Given this list of marker genes H2BC6, H2BC21, HMGA1, CCNA1, H3-4 (NCBI Gene Id 8290), H2AX, TERF2IP, POT1, UBN1, H4C3, H2BC15, TP53, H2AC6, H4C5, H2AC8, H2AC20, H1-0, H2BC7, H2BC17, EP400, H2AC19, H2BC3, MRE11, ASF1A, H2BC1, H2BC26, H2AC4, H1-4, H4C11, H2AB1, KAT5, H2AJ, H4C15, H2BC14, H1-5, H2BC10, ATM, CDKN1B, CDK2, H2AC14, CCNA2, H2BC9 (NCBI Gene Id 8345), TINF2, H2BC11, HIRA, H2AC7, H4C12, LMNB1, CABIN1, H2AC18, NBN, RAD50, CCNE1, CDKN1A, H4C8, H2BC12, H2BC12L, H4C13, H2AZ2, H4C2, H4C9, HMGA2, H4C1, ACD, H4C16, H2BC4, H2BC5, TERF1, H2BC13, CCNE2, H2BC8, H4C6, TERF2, H1-1, H4C14, H1-3, H4C4, RB1, H1-2, here is a description of the gene set: studied in species Homo sapiens DNA Damage/Telomere Stress Induced Senescence Human Gene Set: REACTOME_DNA_DAMAGE_TELOMERE_STRESS_INDUCED_SENESCENCE